Given this list of marker genes ZFP36L1, IGFBP5, NAA15 (N-alpha-acetyltransferase 15, NatA auxiliary subunit), COL5A1, SCN8A, UBE2V1, CCDC152, REEP3, NR3C1, B4GALT6, GRM6, RBPJ, ZNF274, PIP4P2, CIT, PTPN3 (NCBI Gene Id 5774), USP38, RUFY2, SLC6A14, DCX, CYLC1, EMC3 (NCBI Gene Id 55831), TMEM144, SCAMP1, SEPTIN11, ATXN1, PXMP4, CSMD1, RLIM, ALKBH2, PDZD11, HECTD2, GALK2, SEC62, PCDH9, ENO2, KIAA1210, KALRN, SIK3, USP51, TSHZ2, MAGEB6 (MAGE family member B6), INO80D, P2RY1, CHRNA5, MBNL3, PPM1H, VEZF1, BCDIN3D, RNF207, SH3RF1, CDADC1, PEDS1-UBE2V1, ARRDC4, DCANP1, FOXP1, SNAP25, CADM2, DNAH5, NRG1, C4orf46, ANKRD34A, MYT1, SGCB, GSK3A, ZNF280D, DUSP7, CCDC47, SH3TC2, VCP, CERS6 (ceramide synthase 6), CDYL2, DCUN1D5, ZDHHC11, UBE3A, ARPP21, STARD13, ANKRD12, ZNF215, FBXW7, SINHCAF, TRIM2, E2F2, PAK5, BOLA2-SMG1P6, CARF, SORT1, MAP2 (NCBI Gene Id 4133), SGIP1, CNTN5, DCAF8, OTUD4, TRIO, MFSD14A, RBM33, SPARC, MYLK, PAM, STON2, PDPR (pyruvate dehydrogenase phosphatase regulatory subunit), NRN1, ZMYND11, FN1, NMNAT2, SSBP2, NPTX1, ARIH1, INIP, CEP170, ERLIN1, ELAVL4, ATP8B2, EPCAM, MAGEB4, TRIM33, CREBZF, PHF14, REEP1, POLR2J, here is a description of the gene set: Genes predicted to be targets of miRBase v22 microRNA hsa-miR-4318 in miRDB v6.0 with MirTarget v4 prediction scores > 80 (high confidence targets). Human Gene Set: MIR4318 from publication Chen Y, Wang X (PMID 31504780) species: Homo sapiens